Given this list of marker genes Gmppa, Pacsin3, Nf1, Limch1, Alyreffm11, Nutm2, Nalcn (sodium leak channel, non-selective), Ucp3, Lyn, Enpp6, Smap1, Dpp4, Uncx, Klrc1, Dennd4a, Cln8, Sh2d5, Alyreffm17, Eif1ad, Tmem19, Xk, Alyreffm14, Tead3, Tmem245, Tceal7, Tgtp1, Clip3, Patz1, Dtna, Ddx27 (DEAD box helicase 27), Alyreffm15, Lrrtm1, Scn3b (sodium channel, voltage-gated, type III, beta), Zfp712, Semp2l2a, Alyreffm16, Matcap2, Fchsd1, Alyreffm13, Zfp36l1, Syn1, Ubxn6, Dnd1, Nckap5, Csf1, Clip1, Tgtp2, Tmf1 (NCBI Gene Id 414107), Nfe2l1, Pcdh15, Alyreffm10, Zmat4, Clec2e, Itprid2, Cfap70, here is a description of the gene set: Mouse Gene Set: MIR_193B_5P Genes predicted to be targets of miRBase v22 microRNA mmu_miR_193b_5p in miRDB v6.0 with MirTarget v4 prediction scores > 80 (high confidence targets). species: Mus musculus from publication Chen Y, Wang X (PMID 31504780)